Given this list of marker genes GABBR2, CDC42EP1, PRRX2, EDN1, EXO1, SLC26A2, LALBA, MICALL1, GPR161 (G protein-coupled receptor 161), IGHG1, PTPN14, MYBL1, NEFH, CENPF, ADAM17, BAG2, HELLS, PDAP1, RAD54L, ASNS, NPR3, PBK, DUSP9, ACTG2, MUC16, IRX4, LOX, PTPRZ1, DSG1, FZD7, SLC7A5, GBP1, GAL, GMDS, REG1A (regenerating family member 1 alpha), KRT23, IGHV3-7 (immunoglobulin heavy variable 3-7), SERPINH1, APBA2, SFRP1, PALS2, SNTB1, S100A2, SIK1, ROPN1, TTYH1, PRAME (NCBI Gene Id 4136), CDYL, CCL7 (C-C motif chemokine ligand 7), IFNAR2, LAD1, TRIP13, RASAL1, SOSTDC1, STIP1, WNT6, AGBL5, SKP2, LDHB, DEPP1, HLA-G, CHRM3, PEG3, DDX17, ECHDC1, MAGED4B, SYNM, HRK, ISG20, AK2, LMO4 (NCBI Gene Id 8543), MYO10, DEFB1, CD44, UPP1, COCH, LAMC2, FAM107A (NCBI Gene Id 50803), GGH, KLF5, HOXA9, S100A1, COTL1, PAK1IP1, YWHAE, CSRP2, STXBP6, ITGA6, CBS, TUSC3, SET, PADI2, SERPINB4, FAT1, RAB6B, RCAN1, TRA2B, CAPN6, CDC25A, SLC16A1, SHCBP1, CHODL, CDT1, IGHV3-33, CLDN1, COL9A3, CHAF1A, S100A4, PRDM13, CALD1, TYMS, CALU, RGS20, CLCN4, ACTL8, CHML, IGF2BP3, FERMT1, TUBB2A, APOBEC3B, YBX1, CALB2, ENO1, MAPK8, MCM4, STEAP1B, PTP4A3, FBXO17, TMSB15A (thymosin beta 15A), CDCA3, VASH2, FOXD1, IGHV1-69, LAMB3 (NCBI Gene Id 3914), ITGB8, SLC2A6, NES, PXDN, CCL2, MKI67, DKC1, CDH19, UGT8, ADORA2B, IGKV1OR2-108, MYBL2, DNAJC6, LBR, TP53, MOCOS, C16orf95, GABRP (gamma-aminobutyric acid type A receptor subunit pi), DSG3, PRKCA, DKK1, CA5BP1, KLHL24, CD24P4, NUDT1, PFN2, CDC5L, SOX11, KIF18B, ADGRG2, FSCN1, KRT15, TSN, CX3CL1, NUP93, CACNA1A, MSN, EDN2, LYPD1, NXN (nucleoredoxin), ST8SIA1, SLC34A2, KLF6, THEMIS2, SLC43A3, SLC15A1 (solute carrier family 15 member 1), SMCO4, H2BC12L, MAGEA2, NT5DC2 (NCBI Gene Id 64943), RGS2, FOXM1, MMP7, SUSD5, PLIN2, BCL11A, PCSK1N, PART1, MFAP2, TNNI2, FXYD5, IGKV2D-28, IDO1, LGR5, NR6A1, ACTN1, CRYAB, PLCB4, IGKV1D-39, CTAG1B, SIX3, LRFN4, LTBP1, UBE2E3, IGHV4-61, NUDT11, RBP1, CHST3, PTX3, NAP1L1, PROM1, IFI16, SHOX2, PKP1, MCM5, NDRG1, TNFRSF11B, NMU, CDKAL1, IGHV3-23 (immunoglobulin heavy variable 3-23), MAGEA9, ACTA1, GSTP1, ARPC4, TREM1, DLAT, MCF2L-AS1 (MCF2L antisense RNA 1), LCN2, E2F3, P3H2, YBX3, DUOX1, PAX6, KIF1A, TEAD4, TMEM100, CCL20, IL12RB2, HAPLN1, SRD5A1, KRT83 (NCBI Gene Id 652010), CAND2, CHEK1, EGFL6, PI3 (NCBI Gene Id 5266), CXADR, CYB5R2, LY6D (lymphocyte antigen 6 family member D), TRIM29, PSAT1, WNT5B, IL1R2, CDK1, FNDC3B, DNAH17, GJB3, ART3, IFRD1, SOX10, PRELP, BARX1, CHAF1B, NEK2, CXCL5, CXCL10, DLX5, BMAL2, HEPH, ARNT, POU5F1, MCOLN3, RTP4, SYNCRIP, EPHX3, WIF1, FGF9, PTK7, GATA6, PLA2G4A, INAVA, UCHL1, DYNC1I1, TPX2, SLPI, NUSAP1, ACP1, DENND2A (DENN domain containing 2A), KRT6A, CYP26B1, CHST11, KCNG1, IQCG, MRAS, MTAP, ANGPTL4, OGFRL1, NFIB, IGKV1OR1-1, ING1, EGFR, CTSV, ICAM1, QPCT, NSD2 (nuclear receptor binding SET domain protein 2), DSC2, GALNT14, MLLT10, SERPINB3, CHI3L1, ATAD2, TAGLN2, MELK, PTTG1, MFGE8, CEACAM1, EPRS1, VNN1, FZD9, NFE2L3, NPTX2, FUT9, BIRC5, CDH3, TOX, HMGA1, KRT4, PERP, HSPA4L, TTLL4, IMPA2, MET, KIRREL1 (NCBI Gene Id 55243), S100A10, BOP1, CALML5 (calmodulin like 5), CCL5, IGLL3P, PCP4, UCK2, MYLK, RBMS1, SLC2A3, ODC1, SLC25A37, FAT2, PDPN, ID4, MT1X (NCBI Gene Id 82523), SLC27A6, PPM1E, ADCY2 (NCBI Gene Id 254679), CENPE (NCBI Gene Id 1062), FABP7, IFIH1, FOSL1, HYAL1, TRIM2, OCA2, PTGS2, IGKV1D-17 (NCBI Gene Id 28900), CLIC4, BUB1, CA9, AQP5, GSTA1, NCAM1, EN1, ILRUN, ADGRG6, RARRES1, MYC, LAMP3, ODAM, RAB23, KIT, CD38, SIGMAR1, PTGFR, RASA2, TFF2, DSG2, ANGPT1, ANXA3, DLGAP5, SOD2, PLSCR1, MMP1, CA6, CCN2, DBN1, BTG3 (BTG anti-proliferation factor 3), BBOX1, CCL8, FLNA, EPHB3, PFKP, FNDC4 (NCBI Gene Id 64838), GPM6B, ATP13A3, LGALSL, RMND5A, TMEM45A, PRKX, ITPKB, CLEC7A (NCBI Gene Id 64581), PRKD3, FAM171A1 (family with sequence similarity 171 member A1), MMP12, ACAN, ELF5, MCM10, ADD2, SFN, IGF2BP2, MSLN, S100A9, TMCC2, MPZL2, IGLC2, CCL18, DCX, ATP11A, OBP2B, LHX2, TMEFF1, PYGB (NCBI Gene Id 5834), PCDHB3, HS3ST1, PLOD2, ASPM, ZIC1, PVR, MCM7, PLEKHB1, CP, S100B, ARTN, CD59, SLAMF8, BCL2A1, SOCS3, TAP1, TPM2, MRPS12, ST3GAL6, RAP2A (RAP2A, member of RAS oncogene family), MMP14, QKI, CXCL1, PML, HPSE, RPL39L, KRT6B, NCAN, HSPB2, ELF4 (E74 like ETS transcription factor 4), DSC3, TFCP2L1, HTN1, RAD51AP1 (RAD51 associated protein 1), ARHGEF9, VGLL1, DNAJB4, PDZK1IP1, RRAGD, DZIP1, GJC1, COL2A1 (collagen type II alpha 1 chain), PDK1, MAGEA4, PELI1, MAGOH, NCALD, GPSM2, CDKN2A, ELOVL4, AQP9, CCDC88A, KCTD14, CRABP1, TCP11L1, GLS, PEG10, CXCL8, EXTL1, RAD21, NFIL3, KIFC1, KLK10, NRTN, ZNF124, KRT16, ZNF750, IGKV1D-37, HNRNPU, EPB41L2, PLAGL1, HOMER3, FGFBP1, DNM3, KLHL7, GTSE1, TCEAL2, TSPYL5 (NCBI Gene Id 85453), CCKBR, CENPA, NFIX, SCRG1 (stimulator of chondrogenesis 1), TFDP1, TM4SF1, MLC1, PRG2 (proteoglycan 2, pro eosinophil major basic protein), CRLF1, RND3, CEP170, APOBEC3A, KCNN4, KLK6, SOX15, CSPG4, HSPA6, WARS1, MID1, CNN3, TMSB15B, AMD1, KRT14, GDI2 (NCBI Gene Id 2665), DDIT4, CXCL11, COL11A2, LRP12 (LDL receptor related protein 12), LZTS3, MARCO, RRAS2, ZNF532, KCNK5 (potassium two pore domain channel subfamily K member 5), SIM1, LRP8, CDH2, CLDN10 (claudin 10), SERPINB2, CHAC1, MEAK7, GABBR1, KRT81, GPR19, NDC80, TUBB2B, FOLR1, GPR37, VLDLR, CDC45, MAGEA3, TTK, CCNE1 (NCBI Gene Id 898), KHDRBS3, FANCA, KRT17, ANXA8, CENPN, KLK5, L1CAM, PDXK, LYN, ELN, PGBD5, RUNX3, DCPS, IGLV2-14, IL27RA, TMEM158, SOX9, CDCA8, MACROH2A2, MDC1, CLIP4, ORC1, RIPK4, PLAAT1, RYR1, ANP32E, CCNB2 (cyclin B2), NDUFA4L2, NDRG2, HACD1, TNFRSF21, IL32, FOXC1, GALNT12, GART, SLC6A15, S100A6, SMPDL3B, VEGFA, PDE9A, SLC6A14, TBX19, MIA, TIMM44, NKX2-5, CEP55, BACE2, MAP2, KLK7, CCNA2, LEFTY2 (NCBI Gene Id 96286), PRKY, GPRC5B (NCBI Gene Id 51704), PHGDH (phosphoglycerate dehydrogenase), JRKL, SPP1, UBE2S, FOLH1, MTMR2, IGLV3-10, HBEGF, NCAPH, FABP5, PPP1R14B, BYSL, WWTR1, MCM2, ARL4C, CDC20, EMC1, ADM, PLCH1 (NCBI Gene Id 23007), IGKV1D-13, PRSS16, CD24P2, CWH43, COL4A2, KLK8, TDRD12, TCF7L1, SSRP1, S100A8, DMRT1, MALL, MOB3B, SCHIP1, PDGFRA, MDFI, MLLT11, PCOLCE2, YES1, KRT5, SPIB, CYP39A1, MSH6, GLDC, CHI3L2, TXNL4A (thioredoxin like 4A), ITM2C (NCBI Gene Id 9523), SDC2, IGHV4-34, YWHAZ, here is a description of the gene set: Human Gene Set: SMID_BREAST_CANCER_BASAL_UP We explored whether the five previously reported molecular subtypes in breast cancer show a preference for organ-specific relapse and searched for molecular pathways involved. The intrinsic gene list describing the subtypes was used to classify 344 primary breast tumors of lymph node-negative patients. Fisher exact tests were used to determine the association between a tumor subtype and a particular site of distant relapse in these patients who only received local treatment. Modulated genes and pathways were identified in the various groups using Significance Analysis of Microarrays and Global Testing. Bone relapse patients were most abundant in the luminal subtypes but were found less than expected in the basal subtype. The reverse was true for lung and brain relapse patients with the remark that absence of lung relapse was luminal A specific. Finally, a pleura relapse, although rare, was found almost exclusively in both luminal subtypes. Many differentially expressed genes were identified, of which several were in common in a subtype and the site to which the subtype preferentially relapsed. WNT signaling was up-regulated in the basal subtype and in brain-specific relapse, and down-modulated in the luminal B subtype and in bone-specific relapse. Focal adhesion was found up-regulated in the luminal A subtype but down-regulated in lung relapse. The five major molecular subtypes in breast cancer are evidently different with regard to their ability to metastasize to distant organ(s), and share biological features and pathways with their preferred distant metastatic site. species: Homo sapiens from publication Smid M, Wang Y, Zhang Y, Sieuwerts AM, Yu J, Klijn JG, Foekens JA, Martens JW (PMID 18451135) Genes up-regulated in basal subtype of breast cancer samles.